The following is a description of a gene set: species: Mus musculus Mouse Gene Set: GOBP_POSITIVE_REGULATION_OF_INOSITOL_TRISPHOSPHATE_BIOSYNTHETIC_PROCESS Any process that activates or increases the frequency, rate or extent of the chemical reactions and pathways resulting in the formation of inositol trisphosphate., and this is the list of marker genes: Plcd1, P2ry1, Myh9, Lhcgr, P2ry6, Gper1 (G protein-coupled estrogen receptor 1), Pou1f1